Given this list of marker genes C19orf12, GCDH, PLEKHM1, AMPD2, RNU4-2 (RNA, U4 small nuclear 2), TRPV4, ANKH, SCN4A, MT-TH, TBL1XR1, ERBB2 (erb-b2 receptor tyrosine kinase 2), HACE1, MAFA, CYP27A1 (NCBI Gene Id 1593), PLD3, TARDBP, LAMA2, VWA1, MT-ND1, BIN1, MT-ND4, DCTN1, MBD4, GNB2, NEUROG1, CHCHD10, DHH, HINT1, MT-CO1, SURF1, DNMT3A, EXT2, TXN2, AGRN, ALDH18A1, USP48, PRX, SCN9A (sodium voltage-gated channel alpha subunit 9), YARS1, HARS1, TP53, GALC, WDR48, PDGFB, ATP11A, ADPRS, B2M, RYR1, COQ7, SACS, INF2, KIF1B, ELOVL5, CAPRIN1, TTR (transthyretin), VPS41, NR3C1 (nuclear receptor subfamily 3 group C member 1), AGTPBP1, SPRED1, MOCS2, RNF220, PIGB, DHX9, ERCC8, JPH1, PMP22, RAPSN, FLRT1, BAP1, MDH2, SLC25A46, GDAP1, OPA1, ABCA1, FLVCR1, KRAS, TBCD, SPTAN1, SOX10, WARS1, HEXB, TBCE, PIEZO2, MYO1H, LBX1, ARSA, COX6A1, CDKN1A, AIFM1 (NCBI Gene Id 9131), SHMT2, CCND1, CHD7, RRM2B, MPV17, HYCC1, VHL (von Hippel-Lindau tumor suppressor), EDN3, DHX16 (NCBI Gene Id 8449), ATXN3, PIK3R5, POLG2, ZNHIT3, FGD4, GRN, MTTP, KIF5A, MT-TW, PLEKHG5, ELP1, STAT3, SMN2, PRRX1, SLC25A11, PDX1, TFG, PDE11A, DCAF8, MMACHC, SMO, PEX10, CPLANE1, ASXL1 (ASXL transcriptional regulator 1), MT-TV, COASY, SCO2, AFG3L2, NGF, PRNP, COL4A1, FH, GJA1, FXN, TRAF7, MORC2, WNK1, IGHMBP2, SPTBN4, MT-ND6, LRPPRC (NCBI Gene Id 10303), KPNA3, SMARCE1, SBF1, ADCY6, SUFU, FA2H, IFRD1, GJB1, DNM2, IBA57, ERCC6, TTC19, MAX, SPG7, SUMF1, NDRG1, ALG12, MARS1, MT-ND2, USP8, AK9, COG8, MICU1 (NCBI Gene Id 51415), GJC2, PRPS1, DLST, CLCN7, TRPM7 (NCBI Gene Id 54822), YY1, XK, PRRT2, MEN1, LRP1 (LDL receptor related protein 1), MTMR2, TRIM2, PSAP, MPZ, TRAPPC11, TCIRG1, MTMR14, DGUOK, PLEKHG4, PRKAR1A, COL13A1, NTRK1, CTDP1, MT-TQ, SLC52A3, FBLN5, KIF1C, LZTR1, NF2, ACOX1, VPS13A, NF1, ARMC5, PEX16, MYF6, EGR2, PDCD10, MTRFR, PLA2G6, POLG, COQ6, EXOSC9, PIK3CA, CCT5, MOCS1, GCGR, XRCC4, SPTLC2, GBF1, SDHD, TK2 (thymidine kinase 2), GBE1, SYNE1, MEOX1, KLC2, MT-ND3, ATP7A, UBQLN2, ASCC1, VPS13D, ANXA11, CCM2, MME, CYP2U1, PLXNA1 (plexin A1), CHRNA1, KARS1, ATP1A3, ELOVL4, BDNF, TNFRSF11A, SAMD9L, KRIT1, ATP13A2, TERT (telomerase reverse transcriptase), LIG3, TNFSF11, COCH, MATR3, PNPLA6, TRIP4, FUS, APC, PMP2, RNF43, WFS1, NOD2, GMPPA, MT-TE, HNRNPA2B1, SQSTM1, GAN, MT-TK, AARS1 (alanyl-tRNA synthetase 1), TYMP, DDHD1, ATAD3A, DARS2, MAPT, SETX, PHOX2B, BAG3, INS (NCBI Gene Id 3630), BRAF, HMBS, GDF6, ATL1, CDKN1B, SLC25A19, CEP126, TSC1, LMNA, UBTF, PRICKLE1, CDKN2C, DOK7, FIG4, VCP, RTN2, SPTLC1, MLH1, TWNK, EPAS1, NEFH, ASCL1, SEPTIN9, NGLY1, SDHC, ALS2, SDHAF2, SERPING1, GNAS, SLC25A21, PLP1, NEFL, DYNC1H1, IFNG (NCBI Gene Id 3458), NEMF, TUBB3, MT-CO3, COX20, LITAF, HNRNPA1, COLQ, KDM1A, COA7, FLNC, SEMA3E, RET, LAMB2 (NCBI Gene Id 3913), DNMT1, MCM3AP, LRP4, MT-ND5, AKT1, ARHGEF10, SPG11, HSPB1, ATRX, TREM2, KCNJ11, CHRNB1, PLOD1, CDH23, KLHL9, TMEM127, TDP1, SPTBN1, GDF3, OTX2, NAGA, SBF2, PRPH, MT-CO2, TBK1, CHRNE (cholinergic receptor nicotinic epsilon subunit), TYROBP, PSEN1, SH3TC2, APTX, KIF1A, AAAS, KCNJ10, HK1, SOD1, MT-TF (mitochondrially encoded tRNA-Phe (UUU/C)), TMEM53, REEP1, MT-ATP6, CACNA1A (calcium voltage-gated channel subunit alpha1 A), PNPT1, RNF170, EXOSC8, RAB7A, ABCC8, TGFB1, TSC2, TMEM106B, SCN1A, KCNK9, ABCD1 (ATP binding cassette subfamily D member 1), SMARCB1, CDKN2B, GCK, KIT, ATP1A2, MUSK, DKK1, MFN2, SLC12A6, GBA2, C9orf72, RETREG1, LRSAM1, MT-TL1, PTRHD1, EXT1, FGF14, SMN1 (survival of motor neuron 1, telomeric), GDNF, ATL3, SDHA, MAT1A, HSPB8, CHMP2B, CHRND, CA2, FGF3, SDHB, VRK1, SLC25A4, ASAH1, HRAS, MT-TS2, GNB4, CTSD, RAI1, CAPN1, ZFYVE26, SLC29A3, NFU1 (NFU1 iron-sulfur cluster scaffold), SNX10, EXOSC3, GNAQ, UBA1, GFPT1, RFC1, GLE1, UCHL1, here is a description of the gene set: species: Homo sapiens A structural abnormality of the peripheral nervous system, which is composed of the nerves that lead to or branch off from the central nervous system. This includes the cranial nerves (olfactory and optic nerves are technically part of the central nervous system). Human Gene Set: HP_ABNORMAL_PERIPHERAL_NERVOUS_SYSTEM_MORPHOLOGY Abnormal peripheral nervous system morphology